The following is a description of a gene set: from publication Cui A, Huang T, Li S, Ma A, Pérez JL, Sander C, Keskin DB, Wu CJ, Fraenkel E, Hacohen N (PMID 38057668) Cytokines mediate cell-cell communication in the immune system and represent important therapeutic targets. A myriad of studies have highlighted their central role in immune function, yet we lack a global view of the cellular responses of each immune cell type to each cytokine. To address this gap, the authors created the Immune Dictionary, a compendium of single-cell transcriptomic profiles of more than 17 immune cell types in response to each of 86 cytokines (>1,400 cytokine-cell type combinations) in mouse lymph nodes in vivo. A cytokine-centric view of the dictionary revealed that most cytokines induce highly cell-type-specific responses. For example, the inflammatory cytokine interleukin-1β induces distinct gene programmes in almost every cell type. A cell-type-centric view of the dictionary identified more than 66 cytokine-driven cellular polarization states across immune cell types, including previously uncharacterized states such as an interleukin-18-induced polyfunctional natural killer cell state. Genes positively differentially expressed in cell type: MigDC (migratory dendritic cell) upon treatment with cytokine: IL-1α in mouse lymph nodes in vivo. species: Mus musculus Mouse Gene Set: CUI_MIGDC_IL1A_RESPONSE_UP, and this is the list of marker genes: Chp1, Irf5, Tnip2, Hsf2, Calm1, Lcp1, Pdcd4 (NCBI Gene Id 28204), Gpr183, Tuba1b, Nrros, Sh3bgrl, Tmem131, Stx12, Dnajb6, Zbtb18, Aldh9a1, Rel, Aldh1a2, Jaml, Tmem70, Pde4b, Cd80, Il15ra, Coro2a, Ccdc71l, Auh, Cirbp, Tes (testin LIM domain protein), Stxbp6, Tspo, S100a11, Mmd, Sphk1 (sphingosine kinase 1), Rras2, Suv39h2, Actn1, Ptpn2, Fabp5, Pik3r5, Acadm, Fchsd2, Bcl2a1b, Zbtb38, Runx3, Cd83, Rai14, Hcls1, Cox17, Pnp, Arid5a, Hax1, Sh3pxd2b, Csrp1, Atrnl1, Ccl17, Kif3b, Pim1, Serpina3g, Vim (NCBI Gene Id 22352), Macroh2a1, Wfdc17, Plgrkt, Gadd45g, Npc2, Bcl2l11, Sumo2, Snx10, Cd82, Vdr (NCBI Gene Id 22337), Pkib, Iscu, Ikzf4, Litaf, Serpinb6b, Tmbim4, Hnrnpa3, Eif1a, Gcnt2, Tpm4, Sema7a, Tspan13, Mt2, Nae1, Pnkd, Ehd1, Ptpn1, Rab10, Ralb, Gnai2, Prps1, Cish, Abracl, Nup85, Ywhaq, Pdcd1lg2, Ifi47, Slc3a2, Fcf1, Tmpo, Slc27a3, Fas, Crem, Mapre2, Atp6v1b2, Cyth1, Ktn1, Slfn2, Cd274, Ehf, Gbp5, Trim25, Hdac5, Map3k1, Tmed5, Igfbp4, Polr2a, Tax1bp1, Fgl2, Nfkb1, Etv6, Gpbp1, Mif4gd, Atp11a, Glipr2, St8sia4, Akap9, Map4k4, Stk24, Suz12, Palld, Gramd2b, Bcl2a1d, Sap18, Eloc, Riok3 (NCBI Gene Id 66878), Mrpl13, Pfkfb3, Rufy3, Gpd2, Lgmn, Smarce1, Odc1, Tnfaip8, Mkrn1, Alcam (activated leukocyte cell adhesion molecule), Ranbp1, Casp4, Txnrd1, Wnk1, Syngr2, Kctd12, Cyrib (CYFIP related Rac1 interactor B), Fscn1, Prdm1, Serpinb9, Eif5a, Pla1a, Wipf1, Rap2a, Adgrg6, Nfe2l2, Acsl5 (acyl-CoA synthetase long-chain family member 5), Socs3, Bbx, Vopp1, Ankrd44, Irf8, P2rx4, Ifitm2, Nuak2, Bcl7c, Calcrl, Stat3, Ptger4, Mt1, Nr4a3, Stat1, Clta, Hpcal1, Rbm3, Rapgef6, Fyn, Nampt (nicotinamide phosphoribosyltransferase), Ube2l6 (ubiquitin-conjugating enzyme E2L 6), Bcl2l14, Fth1, Ikzf1, Jdp2, Il10ra, Atp11b, Mir155hg, Apaf1, Socs1, Jak2, B2m, Cdkn1a, Anxa2, Ahnak, Mxi1, Chd7, Siglecg, Cnn3, Mefv, Sema4a, Cd63, Fosl2, Tagln2, Etnk1, Clic4, Zyx, Dusp1, Nap1l1, Txndc17, Ube2h, Il1rn, Rad21, Ndrg1, Pacsin2, Mrtfa, Itga4, Elf2, Rasa2, Nrp2, Cd302, Lipe, Ass1 (NCBI Gene Id 11898), Id2, Xbp1, Anxa7 (NCBI Gene Id 11750), Gpcpd1, Cacna1d, Cmtm6, Wdr1, Igsf8, Gpr132, Stxbp3, Pdlim4, Basp1, AA467197, Phlpp1, Lpcat1, Cask, Dnajc10, Ncoa7, Manf, Pik3r1, Ly75, Tmco3, Ramp3, Cd81, Lactb, Agps, Bcl2a1a, N4bp2l1, Selplg, Cst3, Tbc1d8, Ly96, Psma7, Map1lc3b, Tmem131l, Ube2f, Emd, Vdac2, Cd200, Psen2, Psma6, Plk2, Adam19, Got1, Dbi, Arl1, Rap2b, Npr1, Psd3, Metrnl, Tmbim1, Rgs12, Flnb, Nrip1, Rpain, Samsn1, Aff1, Epb41, Dph5, Ccr7, Srgn, Ccl22, Atp6v0a1, Adprh, Ccl5, Plekha1, Rab8b, Snap23, Rac1 (Rac family small GTPase 1), Tcf4, Ddit4, Abtb2, Marcksl1, Itm2c, Slc33a1, Txn1, Sptbn1, Rnf19b, Il1b, Prr13, Nfil3, Stat4, Nudt9, Samhd1, P2ry10 (purinergic receptor P2Y, G-protein coupled 10), Cyfip1, Dhx15, Pmepa1, Cd86, Gbp2, Rfk, Cytip, Actg1, Pdlim5, Nupr1, Orai1 (NCBI Gene Id 78292), Nup88, Nostrin, Necap2, Nckap1l (NCK associated protein 1 like), Ggta1, Plscr1 (phospholipid scramblase 1), Noct, Myl12a, Pigyl, Eif6, Map3k14, Per1, Zfp398, Slc25a3, Lrrfip1, Nfkbia